The following is a description of a gene set: studied in species Mus musculus from publication Chen Y, Wang X (PMID 31504780) Mouse Gene Set: MIR_7230_5P Genes predicted to be targets of miRBase v22 microRNA mmu_miR_7230_5p in miRDB v6.0 with MirTarget v4 prediction scores > 80 (high confidence targets)., and this is the list of marker genes: Tsr1, Fscb (NCBI Gene Id 639685), Zfp975, Mlip, Mlec, Sde2, Zcchc9, Lbhd1, Aff3, Gm14325, Alg5, Etnk1, Slc39a9, Gosr1, Gclm, Snrpn, Zfp970, Trir, Cfl2, Clint1, Zfp976, B4galt1, Gm14322, Gm14296 (NCBI Gene Id 76958), Zfp1009, Ehmt1, Fbn2, Chil6, Dusp1, Fam91a1, Patj, Tox, Lpp, Epc2, Usp32, Nbea, Gm14391, Atp5f1a, Dgkd, 1810009A15Rik, Ak2, Tmem167, 2210418O10Rik, Afg2a, Dlg2, Fam8a1, Stk39, Dixdc1, Vwa3a, Ubfd1